Given this list of marker genes PLP2, H3C11, DCBLD2, CRIP1, ISG15, EXTL1, RELN, AGRN (agrin), EPHA2, CCL23, KIAA0930, DUSP1, SERPINE1, BMP3, FAM216A, CDKN1A, SMURF1, FZD1, GPX1, CD5, PFKFB3, LRRTM2, RASA3, TYRO3, TNFSF14, ATP4B, CAPN9, NTS, ATP2A1, DDIT4, ST3GAL2 (NCBI Gene Id 729518), PON3, TNF, IL6R, TSHR, DKK3, PNPLA6, FOSL2, APOBEC3G, PNP, LY9, DUSP2, SPAG1, RHOH, ELAVL4, OLIG2, RGS16, EPB42, CXCL11 (NCBI Gene Id 6373), ITPR3, SNX3, HES1, SLC16A3, NR4A1, IFNGR2, ZNF821, PTP4A1, KIF22, NAALADL1, PFKL, PTPRT (NCBI Gene Id 11122), GRAP, EPHB6, HFE, TMEM47, ID3, GRAMD4, DSCAM, VOPP1, MAGI2, ZNF652, KLHDC3, TNFRSF1B (NCBI Gene Id 7133), FOXO1, SNRPB, GNAQ, EPHB2, MAFK, LRRN2, RHOBTB3, INSIG1, MAP2K2, CCL3, LMO2 (NCBI Gene Id 8051), GPR68, GABRP, IGLV1-44, AKAP8L, PGM5, H1-3, GNRH1, BCLAF3, SERPINB9, NTSR1, ZNF165, CD6, TCF4 (transcription factor 4), NIPBL, FGF12, RCE1, RUNX3, FLT1, SSX1, RTCA, NDUFA7 (NCBI Gene Id 4701), NR0B1, LINC01138, OR2H2, CDK5R2, SYT5, DIXDC1, CD9, TOM1, DPF1, CCPG1, JRK, IFT27, PDZK1, FKTN, SLC31A1, MAD1L1, TNFRSF10B, DIO1, ALAS2, GP9 (glycoprotein IX platelet), MINDY2, RBPJ, ADGRE5, CXCL2, UBTF, PCSK1, TNFRSF11B, CXADR, ZNF81, MALT1, DDN, OCM2, PSEN1, MYT1L, GSTO1, CCDC106, GNG4 (G protein subunit gamma 4), UBR5, LAMA3, ITPKB, MAEA, SIK3, CACNA1G, DDX6, SEMA3E, GRIK3, CA2, ANXA2P1, TMPRSS2, F3 (NCBI Gene Id 99486), VAC14, KIAA0513 (KIAA0513), TCEA2, CDIPT, SPRY2, ARHGEF1, GADD45B, EPAS1, ENDOD1, MAGEB1, KALRN, OTC, SDHC, NMU, UPF1, TGFB1, HOXB2, S100A7, MAP3K3, TGIF1, LYRM1, PLIN2, ELK3, TUBA4A, MARCHF2, NPAS3, MAB21L1, NINJ1, LY6D, SUSD5, SPATA2, HMGA1, DMXL2, SYDE1, GTF3C2, HTT, IGF1R, VAMP1, GRB7, DMPK, SULT1A1, SPICE1, RGS10, GRIN2D, here is a description of the gene set: from publication Rayner KJ, Sheedy FJ, Esau CC, Hussain FN, Temel RE, Parathath S, van Gils JM, Rayner AJ, Chang AN, Suarez Y, Fernandez-Hernando C, Fisher EA, Moore KJ (PMID 21646721) Genes down-regulated in atherosclerosis macrophages: control anti miR ctrl versus untreated. studied in species Homo sapiens Inhibition of miR-33 results in increased cholesterol efflux and HDL-cholesterol levels in mice. In this study we examined the effect of miR-33 inhibition in a mouse model of atherosclerosis and observed significant reduction in atherosclerotic plaque size. At the end of the study, gene expression in macrophages from the atherosclerotic plaques was assessed. The results demonstrated a reduction in inflammatory gene expression and increased levels of mRNAs containing miR-33 binding sites. Human Gene Set: GSE28783_CTRL_ANTI_MIR_VS_UNTREATED_ATHEROSCLEROSIS_MACROPHAGE_DN